Given this list of marker genes CENPT, SUGT1, DLGAP5, TRAPPC12, KNTC1, CENPA, CENPF, RNF4 (ring finger protein 4), SENP6, CENPH, CENPC, CENPX, CENPK, POGZ, CENPE, CENPW, MIS12, here is a description of the gene set: Human Gene Set: GOBP_KINETOCHORE_ASSEMBLY studied in species Homo sapiens The aggregation, arrangement and bonding together of a set of components to form the kinetochore, a multisubunit complex that is located at the centromeric region of DNA and provides an attachment point for the spindle microtubules.